The following is a description of a gene set: ALK1 signaling events Human Gene Set: PID_ALK1_PATHWAY from publication Schaefer CF, Anthony K, Krupa S, Buchoff J, Day M, Hannay T, Buetow KH (PMID 18832364) studied in species Homo sapiens, and this is the list of marker genes: CSNK2B, SMAD4, TLX2, SMAD7, ACVR2A, TGFB3, TGFB1, ACVR2B, SMAD9, MAPK3, ARRB2, GDF2, ID1, BMPR2, PPP1CA, FKBP1A, ACVR1 (NCBI Gene Id 90), INHBA, CAV1, ENG, MAPK1, ACVRL1, TGFBR2, SMAD5, TGFBR1, SMAD1